Given this list of marker genes BTF3P12, RPL17P31, RNA5SP269, ENSG00000254337, TCF24, LINC00967, RNU7-102P, SNORD87, PRDM14, PPP1R42, MYBL1, RNU6-1324P, ARFGEF1-DT, RN7SKP29, VXN, PREX2, MCMDC2, COPS5, NACAP10, EYA1, C8orf34, MSC-AS1, LINC01603, TPM4P3, RNA5SP268, CSPP1, LINC01592, ADHFE1, ARFGEF1, VCPIP1, PDE7A, RRS1-DT, SUMO2P20, H2AZP2, SLCO5A1-AS1, CPA6, RPS15AP25, RN7SL203P, RPL31P40, PDE7A-DT, ARMC1, SGK3, C8orf44, LACTB2-AS1, RN7SL675P, C8orf44-SGK3, TRAM1, CRH, SDCBPP2, MSC, LINC03020, RNU1-101P, TMX1P2, NCOA2, PPIAP86, PTTG3P, LINC01299 (NCBI Gene Id 286186), LINC00251, ENSG00000200191, TRIM55, ENSG00000255206, RPL31P41, SLCO5A1, MTFR1, RN7SL19P, SNHG6, TRAPPC2P2, RPS20P20, RNA5SP270, SULF1, DNAJC5B, NDUFS5P6, RNY3P14, C8orf34-AS1, XKR9, LACTB2, RRS1, here is a description of the gene set: studied in species Homo sapiens Human Gene Set: chr8q13